Given this list of marker genes SIPA1 (signal-induced proliferation-associated 1), YWHAB (NCBI Gene Id 7529), PRKG1, RASGRP1, RAP1B, RAP1A, PRKACB, RAP1GAP, RAF1, RAP1GAP2, RAPGEF4, RASGRP2, RAPGEF3, PRKACA, PRKACG, YWHAZ, here is a description of the gene set: species: Homo sapiens Rap1 (Ras-proximate-1) is a small G protein in the Ras superfamily. Like all G proteins, Rap1 is activated when bound GDP is exchanged for GTP. Rap1 is targeted to lipid membranes by the covalent attachment of lipid moieties to its carboxyl terminus. Movement of Rap1 from endosomal membranes to the plasma membrane upon activation has been reported in several cell types including Jurkat T cells and megakaryocytes. On activation, Rap1 undergoes conformational changes that facilitate recruitment of a variety of effectors, triggering it's participation in integrin signaling, ERK activation, and others. part of: Adaptive Immune System Reactome Pathway: Rap1 signalling